Given this list of marker genes SRGAP2C, EFNA1, NLGN1, DTNBP1, HDAC2, GRIN3A, NGEF, APOE, FSTL4, PTPRS, here is a description of the gene set: studied in species Homo sapiens Human Gene Set: GOBP_NEGATIVE_REGULATION_OF_DENDRITIC_SPINE_DEVELOPMENT Any process that decreases the rate, frequency, or extent of dendritic spine development, the process whose specific outcome is the progression of the dendritic spine over time, from its formation to the mature structure.